The following is a description of a gene set: A G protein-coupled receptor signaling pathway initiated by tachykinin binding to its receptor on the surface of a target cell, and ending with the regulation of a downstream cellular process. Tachykinin is a short peptide with the terminal sequence (Phe-X-Gly-Leu-Met-NH2). Human Gene Set: GOBP_TACHYKININ_RECEPTOR_SIGNALING_PATHWAY species: Homo sapiens, and this is the list of marker genes: TAC4, GRK5, TAC3, GRK2, TACR2, TACR3, TACR1, TAC1